The following is a description of a gene set: The joining of the small ribosomal subunit, ternary complex, and mRNA. studied in species Homo sapiens Human Gene Set: GOBP_FORMATION_OF_TRANSLATION_PREINITIATION_COMPLEX, and this is the list of marker genes: MCTS2, MCTS1, EIF2S2, EIF2D, EIF2S3, EIF4H, DHX29, EIF4B, EIF2S3B, DENR, RPL13A